Given this list of marker genes LRP8, CENPN, TOP2A, ANP32E, DKC1, CDCA8, CDC45, KRT16 (NCBI Gene Id 3868), CCNE1, CDCA3, CDC20, NDC80, SLC7A5, TTLL4, NCAPH, VGLL1, MYBL2 (NCBI Gene Id 4605), TPX2, here is a description of the gene set: Genes down-regulated in the luminal A subtype of breast cancer. species: Homo sapiens We explored whether the five previously reported molecular subtypes in breast cancer show a preference for organ-specific relapse and searched for molecular pathways involved. The intrinsic gene list describing the subtypes was used to classify 344 primary breast tumors of lymph node-negative patients. Fisher exact tests were used to determine the association between a tumor subtype and a particular site of distant relapse in these patients who only received local treatment. Modulated genes and pathways were identified in the various groups using Significance Analysis of Microarrays and Global Testing. Bone relapse patients were most abundant in the luminal subtypes but were found less than expected in the basal subtype. The reverse was true for lung and brain relapse patients with the remark that absence of lung relapse was luminal A specific. Finally, a pleura relapse, although rare, was found almost exclusively in both luminal subtypes. Many differentially expressed genes were identified, of which several were in common in a subtype and the site to which the subtype preferentially relapsed. WNT signaling was up-regulated in the basal subtype and in brain-specific relapse, and down-modulated in the luminal B subtype and in bone-specific relapse. Focal adhesion was found up-regulated in the luminal A subtype but down-regulated in lung relapse. The five major molecular subtypes in breast cancer are evidently different with regard to their ability to metastasize to distant organ(s), and share biological features and pathways with their preferred distant metastatic site. Human Gene Set: SMID_BREAST_CANCER_LUMINAL_A_DN from publication Smid M, Wang Y, Zhang Y, Sieuwerts AM, Yu J, Klijn JG, Foekens JA, Martens JW (PMID 18451135)